The following is a description of a gene set: studied in species Homo sapiens Human Gene Set: GSE14308_NAIVE_CD4_TCELL_VS_INDUCED_TREG_DN Genes down-regulated in comparison of naive CD4 T cells versus induced regulatory T cell (Treg). from publication Wei G, Wei L, Zhu J, Zang C, Hu-Li J, Yao Z, Cui K, Kanno Y, Roh TY, Watford WT, Schones DE, Peng W, Sun HW, Paul WE, O'Shea JJ, Zhao K (PMID 19144320) Multipotential naïve CD4+ T cells differentiate into distinct lineages including T helper 1 (Th1), Th2, Th17, and inducible T regulatory (iTreg) cells. The remarkable diversity of CD4+ T cells begs the question whether the observed changes reflect terminal differentiation with heritable epigenetic modifications or plasticity in T cell responses. We generated genome-wide histone H3 lysine 4 (H3K4) and lysine 27 (H3K27) trimethylation maps in naïve, Th1, Th2, Th17, iTreg, and natural (n)Treg cells. We found that although modifications of signature cytokine genes (Ifng, Il4, and Il17) partially conform to the expectation of lineage commitment, critical transcription factors such as Tbx21 exhibit a broad spectrum of epigenetic states, consistent with our demonstration of T-bet and IFN-gamma induction in nTreg cells. Our data suggest an epigenetic mechanism underlying the specificity and plasticity of effector and regulatory T cells and also provide a framework for understanding complexity of CD4+ T helper cell differentiation., and this is the list of marker genes: ALG14, DDX18, TNFAIP8L1, GNPNAT1, ANAPC10, PARD6A, PECR, CRYL1, GPN3, STK40 (serine/threonine kinase 40), USP22, ISY1, SNF8, PSMB4, PIK3AP1, SLCO3A1, SPATA2, TMEM241, CALHM5, MBD1, MFSD12, WNT10B, UPP1, CBX2, MECR, EGFL7, ATXN2L, CRYZ, ITGB1BP1, CDC14B, SERPINB1, PINX1, SLC35A4, NDUFS5, CHPF, RPL3, SEC22B, TOMM7, PLAU, SPRED1, ENTREP1, HELB, ARFGAP3, KCNK5, ECI1, CD82, SLC39A2, KDM4A, MAP2K2, ZNF319, PRKCSH, LHFPL6, PBX3, NOC3L, ADIPOR2, RBBP5, CMTM6, LRFN4, PCYT1A, METTL2B, HS2ST1, NR4A2, COX6B1, DHX32, GID8, TMA16, C9orf72, RHOG, STRBP, RARG, MRPL14, NAXE, ATP6V0D1 (ATPase H+ transporting V0 subunit d1), ZYX, PPP2R3C, TNFSF14, BAX, NFKBIE, ISCA2, USP6NL, NME6, GFUS, FLYWCH2, PRKCH, PPM1D, OXSR1, TPD52L2, EXTL1, ZNF608, PLD4 (phospholipase D family member 4), AP1S3, ATP5F1A, ZNF239, PPP1R16A, RXFP2, ABI2, NDUFS3, TM9SF4, EIF2B4, WDR6, SUV39H2 (NCBI Gene Id 79723), TMEM30A, DHRS4, EFL1, MIGA1, PRR12, ATP9A, TRAPPC10, NSFL1C, EXOSC9, STMP1, BORA, SLC35F5, ACSM2A, SLC39A1, SEC14L2, NEURL1B, ABCB6, TBC1D9B, FBXO30, PIK3CG, PGPEP1, ANKH, CRYBG1, DRAM1, ATP8B2, LHX2, CARD19, METTL5, STX12, CCKBR, HNRNPA0, ZNF410, C11orf16, MRPL51, VCP, PITPNB, LRRC58, CARS1, THY1 (NCBI Gene Id 94105), RASSF7, DDX21, RBBP4, SLC35D1, SIK2, WDR75, TPPP, HSPA4L, HIC2, NLRX1, SH3BGRL, CGAS, RHEBL1, FAM174A, CDIN1 (CDAN1 interacting nuclease 1), DCAF8, CDC14A, API5, DPYSL2, GPX7, MED23, IFT172, TPD52, PTPN11 (protein tyrosine phosphatase non-receptor type 11), DGKH, CEP76, GSR, RXRA, NDE1, THOC3, MINPP1, CEP152, CFAP418, ECSIT, DIABLO, UFM1, TRIM46, MLH1, ATP5PB, SRSF10, SIRT2, VLDLR (NCBI Gene Id 7436), FAM217B, NELFCD, UNC13A, FLNB, WIPI2 (NCBI Gene Id 51623), KIF20B, SMAD6, CCT3, PSMA1, PRCC, C1orf74, ZFAND2A, ALDH1L2, CAPSL, SMARCD1, CA12, HDAC1, JUNB